The following is a description of a gene set: from publication van Gurp L, Fodoulian L, Oropeza D, Furuyama K, Bru-Tari E, Vu AN, Kaddis JS, Rodríguez I, Thorel F, Herrera PL (PMID 35440614) Transcriptomic signature geneset for human pancreatic delta cells derived from meta-analyzing multiple single cell RNAseq datasets Single cell RNAseq data from human pancreatic islets was downloaded from 7 previously published datasets. Pairwise differential expression was calculated between all islet cell types in each dataset, and results were integrated to compose a core list of ID genes for each cell types, organised primarily on the number of analyses a gene was detected in. A machine-learning based approach was used to threshold which genes were included in the final ID geneses, and these genesets were then cross validated in three independent datasets to demonstrate they outperformed previously published lists of ID genes. studied in species Homo sapiens Human Gene Set: VANGURP_PANCREATIC_DELTA_CELL, and this is the list of marker genes: TPPP3, CALB1, MLPH, FRZB, GABRB3, ADGRL2, MDK, C22orf42, ETV1, SERPINA1, VMP1, DIRAS3, NCOA7, OPRD1, LRFN5, EDN3, PCSK1, CBLN4, NDRG4, MTUS1, F5, ISL1, CADM1 (cell adhesion molecule 1), RASSF6, EYS, ABI3BP, ERBB4, VIM, PRG4 (proteoglycan 4), MS4A8, CASR, SORL1, DHRS2, SST, SLC38A1, ANK1 (NCBI Gene Id 286), RBP4, AQP3, SCD5, SLC17A6, GPX3, UNC5B, BHLHE41, CPB1, NPTX2, PAPPA2, AKAP12, TIMP2, PCP4, EHF, EEIG1, HADH, PDLIM4, SEC11C, RGS2, PLEKHB1, AMIGO2, ARFGEF3, FFAR4, PKIB, BAIAP3 (BAI1 associated protein 3), BCHE, LEPR, TENM3, NLRP1, TMSB4X, LDHA, HHEX (NCBI Gene Id 5556), SYNE2 (spectrin repeat containing nuclear envelope protein 2), S100A6, CD9, CXADR, PSIP1, ABCC9, DPYSL3